The following is a description of a gene set: An abnormality of the conjunctiva. studied in species Homo sapiens Abnormal conjunctiva morphology Human Gene Set: HP_ABNORMAL_CONJUNCTIVA_MORPHOLOGY, and this is the list of marker genes: TACSTD2, AKT1, SLCO1B3, SDHB, ASPH, PSMB4, TNFRSF13C, AP1B1, SEC23B, TLR4, UROD, PLCB4, SHMT2, IGLL1, KAT6A, KLRC4, PSMB8 (proteasome 20S subunit beta 8), PKHD1, RNF168, MAB21L1, DDB2, MAPT (microtubule associated protein tau), ERCC3, CCR1, TCF3, SPI1, PEX6, POLH, WIPF1, USF3, TRIM44, MASP1, RAG1, DNASE1L3, ACVRL1, SMCHD1, NOD2, STAT4, IL12A-AS1, ERCC5, FGF10, SAMD9 (sterile alpha motif domain containing 9), USB1, BTD, DUX4L1, GALNT3, GJB6, BLNK, KRT14, KRT1, HLA-DRB1, ANO10 (NCBI Gene Id 55129), GDF2, MEFV, GATA1, PITX2, IARS2, C4A, TARS1, SLCO1B1, TBK1, APOA1 (NCBI Gene Id 335), FUCA1, UROS, TKT, LBR, KRT10, HLCS, FRG1, STX16, CD19, TP63, VPS33A, SCN9A, IFNGR1, ZFX, PIK3R1, ERCC1, BTK, PLG, AP1G1, GNAS, FGFR3, HLA-B, GSN, ERCC4, PIGA, GTF2E2, FAS, AAAS, SLC39A4, UBR1, CD79A, BTNL2, SF3B2, ERCC8, LIG1, PAX6, MBTPS2, CR2, RECQL, GTF2H5, IGSF3, TNFRSF1A, IL10, FOXC2, IGHM, DUX4, PCNA, KLLN, AEBP1, RAG2, LYZ, ENG, PIEZO1, IL12A, ERCC6, AIRE, RNF125, ERAP1, SDHD, GNAQ, TNFRSF13B, UBAC2, FERMT1, ICOS, PAX1, LRBA, TRAPPC11, LAMA3, IKZF1, SDHC, PTEN, LYN, SETX, FOXC1, CD79B, DACT1, CARS1, PIK3CA, MTTP, FH, HMOX1, KRAS, WAS, PTPN22, SMAD4, XPC, COL17A1, NBN, GMPPA, SASH1, FBN1, NLRP3, FGFR2, GBA1, TFRC, ERF, RNF113A, ERCC2, ATP2A2, ATM, IL23R, NAGA, COL7A1, MPLKIP, KRT4, MANBA, DNMT3B, FGFR1, SREBF1 (sterol regulatory element binding transcription factor 1), GLA, LRRC8A (leucine rich repeat containing 8 VRAC subunit A), ASAH1, STX11, HGD, AARS1, NLRP1, SALL1, CTSA, GJB2, XPA, DKC1, SLC39A7, SCARB2